Given this list of marker genes Ccnd1, Prkag3, B3gnt3, H3c1, H3f3a, Spop, Ptpn6, Rbbp7, Psmc2, Cd3e, Prkag1, H2az2, Psma2, Psmd6, Lck, H3c7, H4c1, H2ax, Tusc3, Csk, H2ac4, Stt3a, H2bc15, Cd3d, H4c9, Psmc1, H3c15, Psmd1, Cd274, Rps27a, Derl1, Derl3, H2bc8, Pdcd1lg2, H2ac23, H3c4, H4c14, H2bc22, Rbbp4, H2ac10, Psma3, H4c6, H3c13 (H3 clustered histone 13), Tmem258, H4c17, Pdcd1 (NCBI Gene Id 18566), H3c10, H2ac8, Cul1, H2ac13, H2ac24, Cdk4, Sel1l, H2ac1, H2ac20, H3c11, Stt3b, Psmd7, Psmd12, H3c3, H2bc13, Ost4, H2bc12, H2bc9, H4c4, H4c8, Dad1, Psma1, Psmc6, H4c11, H2bc27, H2ac22, Ubb, Psmb5, Psma5, Psma7, H4c12 (H4 clustered histone 12), H2ac12, Psma6, Psmb6 (NCBI Gene Id 19175), Psmb4, H3c6, H2bc11, Mib2, H3c2, Cd3g, Psmc3, H4c18, Vcp, H3c8, Erlec1, Psmc4, Psmd13, H2ac6, Psmb7, Ezh2, H2ac7, H4c2, Ddost, H2ac15, Csnk2b, H2ac19, H2bc1, Psmc5, H2bc7, Psma4, H4c3, H2bc3, H2ac11 (NCBI Gene Id 319167), here is a description of the gene set: part of: Regulation of T cell activation by CD28 family Reactome Pathway: Co-inhibition by PD-1 This event has been computationally inferred from an event that has been demonstrated in another species.<p>The inference is based on the homology mapping from PANTHER. Briefly, reactions for which all involved PhysicalEntities (in input, output and catalyst) have a mapped orthologue/paralogue (for complexes at least 75% of components must have a mapping) are inferred to the other species. species: Mus musculus electronically inferred by orthology from the curated human pathway